Given this list of marker genes ADNP, APPL1, GJB6, TBCA, ARL8B, SPAST, SYT11, SNCA, CCT5, CIMAP3 (ciliary microtubule associated protein 3), FGF13, ARL8A (ADP ribosylation factor like GTPase 8A), LRPPRC, VAPB, B4GALT1, IFT74, UXT, RGS2, PDCD5, SLC6A2, DNAI7, SMC3, TAOK1, EMD, CDK5R1, PEX14, GABARAPL1 (NCBI Gene Id 23710), GABARAP, BCAS3, TTLL7, RACGAP1, TBCD, HTT, MAP1S, BBS4, EML4, NDEL1, RANBP10, TRPV4, DLEC1, HDAC6, GABARAPL2 (GABA type A receptor associated protein like 2), PACRG, here is a description of the gene set: Human Gene Set: GOMF_BETA_TUBULIN_BINDING Binding to the microtubule constituent protein beta-tubulin. species: Homo sapiens